Given this list of marker genes Hsp90aa1, Actn1, Atp8b1, Mfsd10, Ush2a, Cltrn, Myl12b, Pls3, Vcl, Trpa1, Espnl, Havcr1, Plb1, Kcnk1, Ift88, Abcb1a, Stx4a, Strc, Cybrd1, Triobp (NCBI Gene Id 545118), Itln1, Ddr1, Ido1, Myo5b, Aqp7, Pvalb, Gna12, Tspear, Slc26a6, Atp6v0a4, Eps8, Slc15a1, Anpep, Pcmt1, B4galt1, Flna, Slc22a12, Slc9a2, Whrn, Mttp, Espn, Minar2, Ush1c, Akp3, Itpr3, Ace2, Actb, Pafah1b1, Slc20a2, Scin, Slc38a2, Pik3cb, Loxhd1, Flnb, Slc5a6 (solute carrier family 5 (sodium-dependent vitamin transporter), member 6), Actr3, Atp7a (NCBI Gene Id 51824), Mme, Ripor2, Myo6 (NCBI Gene Id 60360), Dock4, Slc22a5, Lrp2, Myh10, Pcdh15, Capza2, Nherf4, Myo15a, Grxcr2, Ralgds (NCBI Gene Id 19730), Mkks (NCBI Gene Id 99133), Pkhd1l1, Lima1, Morn4, Drd5, Cdhr5, Slc6a18, Pex19, Clrn2, Pdzd7 (NCBI Gene Id 435601), Slc19a1 (NCBI Gene Id 20509), Vezt, Folr1, Myo1c, Cdh23, Cd36, Slc28a2, Rdx, Myh14, Coro2a, Slc28a1, Slc26a3, Slc9a3, Kncn, Ceacam16, Dnm1l, Fchsd2, Cgn, Mcoln3, Slc6a19, Car4, Prom1, Ace, Shank2, Slc17a4, Myo1d, Gna13, Diaph1, Trpm6, Slc3a1 (solute carrier family 3, member 1), Eps8l2, Prkci, Rapgef4, Capzb, Myo3b (myosin IIIB), Clrn1, Rsph9, Slc2a2, Tprn, Aqp1, Diaph3, Slc6a14, Treh, Dcdc2a, Slc22a21, Slc46a1, Myo1a, Aqp8, Tmc1, Pemt (phosphatidylethanolamine N-methyltransferase), Lct (NCBI Gene Id 226413), Abcg2, Mpp1, Elmod3, Cdhr2, Clic5 (NCBI Gene Id 70662), Slc27a4, Scart1, Actn3, Slc5a2, Slc34a2, Rapgef3, Piezo2, Flii, Fscn2, Nherf2, Gipc1 (NCBI Gene Id 67903), Ptprq, Soat2, Abcg3, Amn, Slc11a2, Anks4b, Piezo1, Slc6a20b, Cdc14a, Enpep, Myo1b, Slco1a5, Lhfpl5, Slc7a11, Vil1 (NCBI Gene Id 22349), Pjvk, Sis (NCBI Gene Id 69983), Lctl, Adgrv1, Myo18a, Slc34a1, Npc1l1 (NCBI Gene Id 278378), Myl6, Cubn, Dab1, Myo7a, Myo1e, Rhoc, Pth1r, Abcc2, Rgs19, Slc7a9, Tmc2, Snx5, Slc26a4, Ocm, Hsp90ab1, Tiam1, Prkcb, Ift20, Pld2, Ankrd24, Slc5a1, Ezr, Myh9, Calb1, Dcxr, Slc23a1, Coro1a, Homer2, Myh11, Nppa, Cib2 (calcium and integrin binding family member 2), Kptn, Myo7b, Pls1, Myo1h, Slc34a3, Calb2, Slc28a3, Capza1, Add3, Tpm3-rs7, Bbs2, Slc5a8, Rac1, Grxcr1, Nherf1, Myo3a, Slc4a7, Twf2, Adcy6, Plec, Pdzk1, Zswim6 (zinc finger SWIM-type containing 6, NCBI Gene Id 67263), Ptger3, here is a description of the gene set: studied in species Mus musculus A cell part consisting of multiple, closely packed actin-based cell projections. Mouse Gene Set: GOCC_CLUSTER_OF_ACTIN_BASED_CELL_PROJECTIONS